The following is a description of a gene set: Laryngeal edema An abnormal accumulation of fluid and swelling in the tissues of the larynx. species: Homo sapiens Human Gene Set: HP_LARYNGEAL_EDEMA, and this is the list of marker genes: PLG, EPHB4, XPNPEP2, SERPING1, HS3ST6